Given this list of marker genes ABCC8, TGFB3, TGFBR2, SMAD3, ELN, FSHR, HEY2, MYO5B, TGFB2, MYH11, AVPR2, TGFBR1, SMAD2, MFAP5, CTNS, AQP2, PRKG1, LOX, STX3, INS, FOXE3, ACTA2, MAT2A, CYP11A1, SMAD4, STAT3, KCNJ11, FBN1, GCK, THSD4, MYLK, PDX1, here is a description of the gene set: studied in species Homo sapiens Abnormality of blood volume homeostasis Human Gene Set: HP_ABNORMALITY_OF_BLOOD_VOLUME_HOMEOSTASIS An abnormality in the amount of volume occupied by intravascular blood.